Given this list of marker genes SUMO1, IGF2R, COL2A1, SREBF2, MEST, ATP5PB, PEG3, NET1, EIF4A2, FGFR3, SMARCA1, HNRNPC, BRD3, SNRPE, ITIH2, BTG3, TARBP1, ABCD3, RPL24, ATP2B1, CSNK2A2, ARHGAP35, ATP2B2, IDI1, PPARG, TBCE, KLF3, ATM, GLUD1, EIF4B, PRDX3, ENPP1, GTF2I, FGFR4, RPS19, SLC6A2, ARID3A, H1-0, TPR, CD46, HNRNPU, HELZ (NCBI Gene Id 9931), DDX18 (DEAD-box helicase 18), HMGCR, RBM39, NR5A2, CXADR, IGF2, PIGC, GTF3C2, BCAM, PNN, PTOV1, SUZ12, RPS25, SMARCC1, GPC3, TP53BP2, EP300 (NCBI Gene Id 2033), TIAL1 (TIA1 cytotoxic granule associated RNA binding protein like 1), RAB4A, TFIP11, CSE1L, CHKA, SSB, CUL4A, UBE2K, CSNK2A1, RPS27, DDX1, AHCY, NR2C1 (nuclear receptor subfamily 2 group C member 1), POFUT1, ATXN10, ERBB3, MAPK6, TM9SF4, SEPHS1, FLNB, NUP153, RPL31 (ribosomal protein L31), TIA1 (NCBI Gene Id 7072), NT5E, SLC6A5, ABCB10, RRP1B, RPL27, CASC3, GCN1, PHF3, CDK6, ACP1, NREP, RPS24, CTNNB1, PPP2R1A, NCOA4, DEK, CPD, ATF2, PLXNB1, RPS5, LBR, GNAI1, CLK2, ADD3, AFP (alpha fetoprotein), SNTB1, PHKA2, HNRNPA2B1, GBF1 (NCBI Gene Id 8729), FBL, TTC3, TRIM26, BCLAF1, here is a description of the gene set: Human Gene Set: HOSHIDA_LIVER_CANCER_SUBCLASS_S2 Genes from 'subtype S2' signature of hepatocellular carcinoma (HCC): proliferation, MYC and AKT1 activation. species: Homo sapiens from publication Hoshida Y, Nijman SM, Kobayashi M, Chan JA, Brunet JP, Chiang DY, Villanueva A, Newell P, Ikeda K, Hashimoto M, Watanabe G, Gabriel S, Friedman SL, Kumada H, Llovet JM, Golub TR (PMID 19723656) Hepatocellular carcinoma (HCC) is a highly heterogeneous disease, and prior attempts to develop genomic-based classification for HCC have yielded highly divergent results, indicating difficulty in identifying unified molecular anatomy. We performed a meta-analysis of gene expression profiles in data sets from eight independent patient cohorts across the world. In addition, aiming to establish the real world applicability of a classification system, we profiled 118 formalin-fixed, paraffin-embedded tissues from an additional patient cohort. A total of 603 patients were analyzed, representing the major etiologies of HCC (hepatitis B and C) collected from Western and Eastern countries. We observed three robust HCC subclasses (termed S1, S2, and S3), each correlated with clinical parameters such as tumor size, extent of cellular differentiation, and serum alpha-fetoprotein levels. An analysis of the components of the signatures indicated that S1 reflected aberrant activation of the WNT signaling pathway, S2 was characterized by proliferation as well as MYC and AKT activation, and S3 was associated with hepatocyte differentiation. Functional studies indicated that the WNT pathway activation signature characteristic of S1 tumors was not simply the result of beta-catenin mutation but rather was the result of transforming growth factor-beta activation, thus representing a new mechanism of WNT pathway activation in HCC. These experiments establish the first consensus classification framework for HCC based on gene expression profiles and highlight the power of integrating multiple data sets to define a robust molecular taxonomy of the disease..